Given this list of marker genes Ehd3, Arl8b, Rab14, Snx2, Snx1, Stx5a, Snx8, Bltp3b, Trappc10, Rbsn, Rab6a, Rufy1 (RUN and FYVE domain containing 1), Rab4b (RAB4B, member RAS oncogene family), here is a description of the gene set: Mouse Gene Set: GOBP_EARLY_ENDOSOME_TO_GOLGI_TRANSPORT The directed movement of substances from early endosomes to the Golgi. studied in species Mus musculus